The following is a description of a gene set: mAChR-Ca2+ -apoptotic pathway. Pathway ID: N01000. Pathway type: Reference. Pathway class: nt06528 Calcium signaling. Human Gene Set: KEGG_MEDICUS_REFERENCE_MACHR_CA2_APOPTOTIC_PATHWAY Pathway Definition from KEGG: ACh -> mAChR -> GNAQ -> PLCB -> IP3 -> ITPR -> Ca2+ -- MCU -> Ca2+(mito) -- MPTP -> CYCS species: Homo sapiens, and this is the list of marker genes: PLCB2, CYCS, ITPR1, ITPR3, SLC25A6, PLCB4, VDAC2, CHRM1, SLC25A5, SLC25A31, PLCB3, GNAQ, CHRM3, VDAC1, MCU, PLCB1, CHRM5, VDAC3, SLC25A4, ITPR2